Given this list of marker genes PDCD10, TGFB2, IGFBP6, RIPK2 (NCBI Gene Id 8767), TAOK3, TAOK1, CARD9, NOD2, EIF2AK2, IL26, STK25, MAPK8IP2, INAVA, TAOK2, TLR4, SEMA4C, MID1, KLHDC10, ARL6IP5, NOD1, SCIMP, here is a description of the gene set: Human Gene Set: GOBP_POSITIVE_REGULATION_OF_STRESS_ACTIVATED_PROTEIN_KINASE_SIGNALING_CASCADE studied in species Homo sapiens Any process that activates or increases the frequency, rate or extent of signaling via the stress-activated protein kinase signaling cascade.